The following is a description of a gene set: part of: Transmission across Chemical Synapses Reactome Pathway: Neurotransmitter receptors and postsynaptic signal transmission This event has been computationally inferred from an event that has been demonstrated in another species.<p>The inference is based on the homology mapping from PANTHER. Briefly, reactions for which all involved PhysicalEntities (in input, output and catalyst) have a mapped orthologue/paralogue (for complexes at least 75% of components must have a mapping) are inferred to the other species. studied in species Mus musculus electronically inferred by orthology from the curated human pathway, and this is the list of marker genes: Ap2a1, Gnb3, Cacng4, Camkk2, Camkk1, Kcnj10, Camk1, Grin2b, Gng10, Prkacb, Gng5, Grip1, Grin2a, Gngt2, Rps6ka6, Gabrr1, Epb41l1, Gngt1, Ap2s1, Grin2d, Chrnb2, Calm1, Kcnj3 (potassium inwardly-rectifying channel, subfamily J, member 3), Prkar2b, Ap2b1, Gabra3, Dlg4, Gnb5 (guanine nucleotide binding protein (G protein), beta 5), Prkaca, Grik5, Gng11, Gng7, Dlg3, Gabra6, Chrne, Chrna7, Prkca, Gng4, Kcnj12, Grin2c, Gnat3, Htr3a, Gnai1, Gnb2, Gabrq, Chrna4, Glra2, Camk2b, Prkar1b, Nsf, Kcnj5, Cacng3, Adcy5, Ap2m1 (NCBI Gene Id 11773), Gabrr2, Gabbr1, Plcb3, Gabrr3, Gng8, Gabrb3 (NCBI Gene Id 14402), Nefl, Gng3, Prkcg, Gabra1, Grin1, Gabra4, Adcy7, Kcnj2, Adcy8, Htr3b